The following is a description of a gene set: studied in species Homo sapiens Phenylalanine and tyrosine metabolism Human Gene Set: REACTOME_PHENYLALANINE_AND_TYROSINE_METABOLISM, and this is the list of marker genes: HPD (NCBI Gene Id 3242), TAT, PCBD1, IL4I1, PAH, ASRGL1, KYAT1, FAH, GSTZ1, QDPR, HGD